Given this list of marker genes FRA10AC1, ATP6V1E1, KBTBD13, TRMT10A, BBS12, CLCF1, VPS33B, TNNT3, PUS1, BSCL2, WT1, SHOX, APC2, ADAMTSL1, COG5, ARL6IP6, CUL4B, ERCC3, NSD1, PRKG2, NUP188, WDPCP (NCBI Gene Id 51057), PIEZO2, LTBP3, SLC6A8, ADGRG6, CENPJ, FARS2, RIC1, COL9A1, RIT1, FAM20C, NAA80, GALNS, CRELD1, MAD1L1, UBA1, MAF, CNTNAP1, RPS27, KNL1, PTCH2, NIPBL, TBL2, SNRPB, PIGT, MAP3K20, ARHGAP29, BRD4, SETD5, RPL15, LARGE1, RAB3GAP1, PNKD, POLE, ERCC5, EZH2, USB1, RMRP, DPAGT1, ATRIP, MAN2B1, PLVAP, IDH1, B3GLCT, SMAD4, VPS13B, FBXL4, CLCN7, SP7, NUP133, DBR1, METTL27, MECP2, PTPN11, NFASC, MIA3, PEX3, UBAP2L, KCNJ5, LMOD3, IARS2, GATA1, FLII, TTC8, MYL11, COL25A1, TNNI2, SMO, RAB23, SFRP4, TELO2, COL5A2, CTSK, PDGFRA, DHODH, FLVCR2, PIGB, STRA6, YRDC, PTEN, ORC1, DGCR8, CCN2, CCDC88A, TINF2, VAMP1, GOLGA2, RAB33B, CHRNA1, PLAG1 (PLAG1 zinc finger), EXOC7, ZNF699, CREBBP, ASXL2, NPHP1, TOE1, TNRC6B, IL2RB, DPYSL5, IGF1R, THOC6, AP3D1, NSRP1, FBXO28, ECEL1, KIF14 (kinesin family member 14), BDNF, SPEN, THUMPD1, COL13A1, KIF26A, PRDM13, ADAMTS10, MAMLD1, FANCB, SCLT1, ATP6V0A1, TOPORS, ANTXR1, CREB3L1, RSRC1, BGN (biglycan), ADAMTS3, NCF1, IDUA, THSD4, RECQL, SATB2, PGAP3, WNT7A, TBX1, ATG7 (autophagy related 7), CPE, YY1, PEX10, PLK4, SCN9A, GTF2IRD1, NDUFB11, COL3A1, MYLK, CASK, DCHS1, CSPP1, WDR26, NSMCE2, KAT6B, SPEG, GRB10, PGM1, ODC1, KLHL41, MAGEL2, FAM149B1, B3GAT3, TRAIP, PPARG, CNTNAP2, SPOP, WRAP53, LGI4, CEP120, MARS1, PARN, B9D1 (B9 domain containing 1), RNU4-2, COL6A3, MYO18B, PALB2, DOCK6, B9D2, MED13L, NPM1, ABCD1, H4C9, CHRNG, KDM5C, SH3PXD2B, CSNK2B, ALG11, RFC2, CTNND2, DKC1, PPP1R15B, RAB34, KAT6A, NOTCH3, UPF3B, ADA2, TGIF1, PIGV (NCBI Gene Id 55650), ALX1, PTH1R, SCN4A, EDNRA, CTCF, MTX2, CSGALNACT1, ZBTB24, CD247, FLNA, NECTIN1, GSC, GTF2IRD2, BPTF, PRR12, LAMB2, BBIP1, P4HTM, PAK2, SCNM1, ARSL (NCBI Gene Id 415), CHUK, RPGRIP1, C1R (NCBI Gene Id 791254), SYT2, SMPD4, ADAMTSL2, NEK9, MAPRE2 (NCBI Gene Id 51683), LZTFL1, NEK1, HEY2 (NCBI Gene Id 30830), TGFB2, BICRA, FLNB, MYH8, BMP4 (bone morphogenetic protein 4), RB1, TBC1D7, CHD7, SLC35B2, IFT74, RPL35, GTF2H5, KIAA0586, BPNT2, RREB1, RPGRIP1L, PCDHGC4, ADGRG1, ACTA1, DNMT3A, VARS1, POGZ, BLTP1, NCAPG2, TSEN54, FANCI, AGPAT2, WBP4, C12orf57, PSMC1, EPG5, TMEM237, GABRA3, RTTN, FOXP1, ADAT3, XRCC4, SPRTN, HDAC9, FKBP6, CBFB, CEP19, BBS10, EXTL3, CSNK2A1, RARB, SVIL (NCBI Gene Id 6840), CLIC2, RPS10, HYLS1, DHCR24, SDCCAG8, GEMIN4, HERC2, NSD2, BBS2, COG7, FKRP, CACNA1C, KIF21A (NCBI Gene Id 80819), VPS37D (NCBI Gene Id 171020), PEX14, SLC29A3, RIN2, CEP152, GDF11, SEC24C, RPL11, NEDD4L, ERGIC1, ORC4, POLR1D, POMGNT1, CWC27, SLC12A6, DONSON, PTPN22, POLR1B, CARS1 (NCBI Gene Id 833), MAPK8IP3, HNRNPH2, STEEP1, RAP1GDS1, LETM1, BIN1, COLQ, TMEM270, AKT1, NFIX, RAC3, RYR3, UBE3B, SLC3A1, KIFBP, PIK3R1, SPRED2, MMP2, SRPX2, RAB18, CENPE, FOXI3, NUP85, PIGQ, PYROXD1, PURA, FGD1, PUS7, TMCO1, TFAP2A, SMC3, RERE, PYCR1, ITGA7, SEC24D, MYH7, MESD (NCBI Gene Id 23184), SHANK3, FANCG, VPS35L, KIF11, TRIM32, TGFBR1, ALDH1A2, NXN (NCBI Gene Id 64359), ARCN1 (archain 1), ATP6V0A2, ATR, KCNH1 (potassium voltage-gated channel subfamily H member 1), ASPM, MOGS, FGFRL1, PHGDH, ITGA8, HOXB1, PPP1R12A, IFT27, BLM, IFT80, PRKG1, ARID1B, TRPS1, ATRX, MRPS22, RNF125, CHST14, SIN3A, BBS7, PEX26, TUBB, CLCN4, GJA1, ANAPC7, HUWE1, IGF1, CAV1, INTS11, PAX6, CCDC22, ALG13, AGRN, OSGEP, FMR1, WWOX, PEX11B, MSX1, KCNN3, RPL18, SLC6A17, OPHN1 (oligophrenin 1), FOCAD, POMT2, SRY, RPS6KA3, PRUNE1, COLEC11, HNRNPK, DYRK1A, RDH11, HNRNPR, TSR2, HBA1, SUZ12, ERBB3, MAN2C1, CLPB, SETBP1, SNRPN, CENPF (NCBI Gene Id 51468), GATA4, DIS3L2, EHMT1, PKDCC, MFAP5, EIF4A2, AIP, BRIP1, COASY (Coenzyme A synthase), KDM5A, DNMT3B, RPS29, FBXW11, SEC23A, MYH11, TRIP11, PEX6, FBN2, RRAS2, SLC5A7, PLAAT3, RTEL1, IFT140, MCTP2, ANO5, DYNC2I1, GATAD2B, ERI1, FGF3, COL6A2, FANCD2, SOBP, BBS4, HS6ST2, NF1 (neurofibromin 1), EXOSC5, PEPD, GNAI3, SETD2, DYM (NCBI Gene Id 54808), COL1A1 (NCBI Gene Id 4970), PHF21A (PHD finger protein 21A), CAMTA1, DICER1, SMAD2, GPC4 (NCBI Gene Id 2239), TERC, MCM5, LIG4, H3-3B, FGF10, GON7, BAZ1B, MAP2K1, TTN, VPS53, PSPH, TGFB1, DGCR2, ZC4H2, UHRF1, EMC1, POLR1A, LBR, EXOSC1, CDC6 (NCBI Gene Id 990), SLC6A9, SOX5, NSUN2, SOS1, TPM3, ACAN, SCARF2, ZNF668, CUL7, CBL, PUF60, EXT1, CHAT, DGCR6, FBXL3, AP2M1 (NCBI Gene Id 1173), UBE3A, STAT3, BBS1, CNTN1, BRAF, IRX5, COL2A1, FOXP2, FANCE, GLB1, TBCD, HELLS, BUB1B, ZEB2, TUBGCP2, PRKACB, TWIST1, DZIP1L, PCGF2, SNIP1, ORC6, MGAT2, DSE, C2CD3, MEG3, PEX7, TONSL, GHR, RAF1, ALG1, HMGA2, TMEM216, KATNB1, SLC35A3, BCL11B, AMMECR1, SMC1A, CACNA1G, SLC35C1, NALCN, DVL1, AGA, HRAS, BNC2 (NCBI Gene Id 54796), SH3BP2, WNT3, NRCAM, RPS7, ABAT, PKHD1, SCO2, EDA, GMNN, INTU, ERMARD, NEB, DDX3X, LZTR1 (NCBI Gene Id 8216), ASXL1, CEP290, SELENON, TPM2, XRCC2, NUDT2, RASA2, OFD1 (NCBI Gene Id 8481), TXNL4A, FOXC2, ACTA2, ZNHIT3, CILK1, AEBP1, NAA10, KMT2A, LAS1L, MYBPC1, ATAD3A, BRCA2, SEC61A1, SOX6, SLC2A10, CLCN3, MRAS, LEMD2, CA2, PEX1, PIK3CA, PMM2, INTS1, PEX13, PIGG, PIGF, CCBE1, CCDC32, MED12, PDGFRB, ELN, CDH11 (NCBI Gene Id 1009), IFT172, DNAJC21, ASNS, CTDP1, HNRNPH1, TCOF1, ATP6V1B2, ASCC3, ATP7A, SPRED1, VAC14, HCCS, IDS, UNC80, PEX12, HNF1B, CLIP2, CEP57, SLC25A19, IGBP1, SLC9A6, MYPN, STAG2, MSTO1 (misato mitochondrial distribution and morphology regulator 1, NCBI Gene Id 55154), GNPTAB, RTL1, NOTCH2, HSPG2, PIGO, KMT2D, ZMPSTE24, FBXO11, DVL3, FIG4, TOR1A, GP1BB, TRPM3, MITF, RRAS, SOST, SEC31A, KCTD1, TMEM231 (NCBI Gene Id 79583), FHL1, MSL3, IGF2, CHRND, TAF4, PLXND1, RLIM, RAP1B, VPS13A, LEMD3, PSMD12, GRIP1, REV3L, SLC35A2, MBD5, MPLKIP, CDC45, PRMT7, SF3B2, BMPER, TENT5A, TRIO, CFAP418, SC5D, C1GALT1C1, GTF2I, COL9A2, NDST1, PSAT1, ZNF335, EED, IBA57, RBM10 (NCBI Gene Id 8241), TNFSF11, TMEM107, PTPN2, IPO8, PRKAR1A, TBCE (NCBI Gene Id 6905), ADAMTS2, RPS17, SKI, IGFALS, PGAP2, NHS, OTUD6B (NCBI Gene Id 51633), SMG8, TP53RK, DLK1, PAX7, NOP10, WDR11, ANKH, BRCA1, AFF3, ZBTB18, CHSY1, TAFAZZIN, DHX30, NR2F1, PCNT, PRRT2, ALG12, MYCN, RAD51, CTC1, CANT1, KRAS, COL11A1, POLR1C, SMAD3, HIRA, SMS (spermine synthase), BICD2, FBN1, AUTS2, CLTCL1, SLC26A2, MAT2A, FGFR2, CHST3, MKKS, RFT1, FANCA, ARL6, PIGA, CHD5, DDX59, CDH1, RIPK4, RPL9, ACTG1, CPLANE1, MYO9A, COL6A1, WASHC5, ZNF292, POLR3A, CRTAP, GLE1, TBC1D2B, KCNJ2, ERCC8, IQSEC2, PREPL, CEP135, UFD1, INSR, DPH1, FLCN, PEX19, SLC4A10, DOCK3, DPH5, PAX3 (NCBI Gene Id 5077), PIGN, BBS9, TAPT1 (NCBI Gene Id 202018), SUFU, ABL1 (ABL proto-oncogene 1, non-receptor tyrosine kinase), TYMS, GORAB, GLI2, NSDHL, WNT5A, CFL2, BUB1, NDE1, CC2D2A, H4C3 (H4 clustered histone 3), FTO, SMC5, DDB1, NUP107, NELFA, ASPH, DPH2, DYNC2I2, CRIPT (CXXC repeat containing interactor of PDZ3 domain), UBB, HEATR3 (HEAT repeat containing 3), LAGE3, RPS19, RPL31, TRRAP, RUSC2, HERC1, LRP5 (NCBI Gene Id 8058), HDAC8, BCAP31, TGDS, RPL35A (ribosomal protein L35a), KIF15, GBA1, EMG1, PYCR2, SOX9, FZD2, FKTN, SUPT16H, SCAPER, KCNJ6 (NCBI Gene Id 8206), FGFR3, TBC1D20, SLC37A4, EIF4H, BBS5, FOXE1, D2HGDH (NCBI Gene Id 728294), GJA5, SLC10A7, DYNC2H1, TMEM67, TPRKB, ARHGEF38, RAD21, CEP295, TBX15, SIX3, BCL11A, DLX4, MED25, OCRL, GJA8, BUD23, SH2B1, ERCC2, GNA11, TAF1, LTBP4, FANCF, HECTD4, SCYL2, SEMA5A, EP300, SPECC1L, RPS15A, EBF3, RAI1, ALG14, DNA2, ERCC1, DSTYK (dual serine/threonine and tyrosine protein kinase), ZBTB11, LAMA2, UBA2, BRAT1, PI4K2A (NCBI Gene Id 55361), SMOC1, RPS24, TBX5, BRF1, KIAA0753, TGFB3, CDT1, TMEM70, MAP3K7, MUSK, FBXO31, KCNK9, ADAMTSL4, RPS28, C1S (complement C1s), ERCC6, ZBTB20, MAD2L2, STAG1, CCNK, CDKN1C, RPL27, WDR73, JARID2, FGFR1, SIX1, SF3B4, RPL26, SALL4 (NCBI Gene Id 57167), HBA2, BANF1, SRCAP, GRHL3, GPR101, COBLL1 (NCBI Gene Id 22837), FILIP1 (NCBI Gene Id 27145), BRCC3, PIK3C2A, PLAA, FOXE3, HDAC6, AP1S2, RBM8A, AIMP2, OTUD5, DNAJC30, TP63, OCLN (NCBI Gene Id 4950), EIF5A, MAPK1, IL6ST, MAFB, ERCC4, ATPAF2, ESAM, PPP3CA, KDM6A, GLDN, CDCA7 (NCBI Gene Id 83879), RUNX2, LMBRD2, GLI3, RSPO2, ESS2, RFX7, HACD1, EYA1, COL1A2, CNOT3, RECQL4, PDE6D, OSTM1, FOXG1, WDR4, RPL10, CDC42BPB, COMT, H3-3A, AFG2B, GRIA3, ATP10A, HNRNPU, DHX9, EXT2, SLC25A24, CRLF1, HYMAI, PEX16, CTU2, PIGY, HS2ST1, AMER1, MTM1, COX7B, FRMPD4, YARS1, LRRC32, COG4, ACTB, TRMT1, ANKRD11, FANCM, SNAP25, FOXF1, FANCL, SERPINH1, KIDINS220, TWIST2, EBP, DOK7, WNK3, COG6, ROR2, TNPO2, GTF2E2, HMX1, GRIA4, NEXMIF, COG8, RNU12, ANKLE2, TRIP13, MIPEP, PHIP, GNB2, ACTG2, ARVCF, EDEM3, COL5A1, MAB21L1, IFIH1, RPS26, CHD8, FOS, CHRNE, DEAF1, CAVIN1, U2AF2, CEP55, DPM1 (NCBI Gene Id 8813), PRRX1, LIMK1, KAT5, KCNC2, STAT4, PRIM1, KPTN, H4C5, PAH, AHDC1, PAX1, IFT43, ROBO1, AFF4, PI4KA, GPC3, IL2RA, RYR1, TUBA1A, SMCHD1, CHN1, POLA1, RPL5, NUP88, OCA2, PLCB4, RELN, ACBD6, DHCR7, UBE2T, LMNA, ESCO2, RPS20, TARS1, ANK1, MEN1, CNOT2, ZDHHC9, TBX4, MKS1, SSR4, MYMX, PRORP, TXNDC15, PEX5 (peroxisomal biogenesis factor 5), ANKRD55, APC, PDE4D, PLA2G6, NHP2, RNF113A, RAPSN (receptor associated protein of the synapse), B3GALT6, POMT1, TBCK, AP4M1, MINPP1, STT3A, NARS1, KDM6B, BMP2, TASP1, ARX, YARS2, CHD6, STAMBP, AFG2A, ZMIZ1, SLC18A3 (solute carrier family 18 member A3), TOMM7, CPLX1, RBBP8, BUB3, PIEZO1, CAPRIN1, NEPRO, TRIP4, PIGW, ZFX, POC1A, LOX, PIGL, MYH3, IL1RAPL1, NRAS, COG1, FANCC (NCBI Gene Id 2176), AARS1, IL11RA, LIFR, SIX5, GPKOW, SOS2, GAD1, ALX4, ARNT2, IRF6 (NCBI Gene Id 7452), RNU4ATAC, ZNF341, CDC73, SLC25A1, TCTN1, DLG1, GNPAT, MADD, OTX2, PEX2 (NCBI Gene Id 5828), POLD1, PQBP1, RAB3GAP2, RFWD3, HSD17B4, HYOU1, TCTN2, KIF7, CTBP1, SOX18, RPL8, EFTUD2, SLC12A2, EFEMP2, FAT4, MAPKAPK5, WLS, KDM4B, FDFT1, ATP6AP2, JMJD1C, EDN1, WDR62, SON, GPC6, RAD51C, ALG9, STX1A, PTCH1, DPYD, WDR35 (NCBI Gene Id 57539), PRKACA, DPM2, GFPT1, KMT2B, RHOBTB2, PITX2, PTDSS1, CDK5, ABCD4, HBB, MYL2, COL9A3, HPDL, ARMC9, MEGF8, TCTN3, MYMK, COL12A1, ASXL3, SLX4, FUT8, STAC3, MYOD1, KCNK4, TUBB3, ALX3, TGFBR2, B4GALT7, TAF6, ARID2, TERT, NBN, CD96, FOXC1, SIM1, DDR2, LRP4, LRPPRC, WBP11, ERF, MID1, CRPPA, EIF4A3, ATP6V1A, PLAGL1, P4HB, COL11A2, here is a description of the gene set: Abnormal jaw morphology Human Gene Set: HP_ABNORMAL_JAW_MORPHOLOGY studied in species Homo sapiens A structural anomaly of the jaw, the bony structure of the mouth that consists of the mandible and the maxilla.